The following is a description of a gene set: Mouse Gene Set: chr8D3 studied in species Mus musculus, and this is the list of marker genes: Gm45710, Mir140, Tmem208, Chst4, Psmd7 (NCBI Gene Id 17463), 5033426E14Rik, Vac14, Hp, Matr3-ps2, Gm3830, D030068K23Rik, Ddx28, Pla2g15, Ap1g1, Cmtm4, Thap11, Gm11020, B3gnt9, Hydin, Mir1966, Fbxl9, Esrp2, Enkd1, Gm16209, Hsd11b2, 4930578M07Rik, Gm5159, Ces4a, Mir7075, Matcap1, 4933405L10Rik, Zfp612, Gm16208, Nqo1, Fbxl8, Gm33023, Cmtm2a, Atp6v0d1, Zdhhc1, Rrad, Rps18-ps3, C630050I24Rik, Hsf4, Wwp2, Gm8838, Ces2c, Bean1, Ces2d-ps, Gm10073, Cdh1, Ces2h, Ranbp10, Fhod1, Gm5743, Vps4a, Gm5915, Gm45795, Tsnaxip1, Gm20163, Ctcf, Ciao2b, Mir7074, 1810019D21Rik, Tppp3, Nol3, Slc12a4, Dpep2, Cog8, Cklf, Gm1943, Gm17344, Mir328, Gm39244, Pard6a, Tradd, Gfod2, Utp4, Cdh16, Cmtr2, Gm45752, Ces2a, Dus2, Gm10629, Phaf1, Gm6831, Gm8798, Gm8940, Txnl4b, Cdh5, Ripor1, Pkd1l3, Edc4, Gm10631, Zfhx3, Tmed6, Pdf, Mir3108, Pdp2, Gm8804, Elmo3, Slc7a6, Marveld3, Gm25321, Smpd3, Nob1, Tle7, Ces2f, Gm45855 (NCBI Gene Id 108167548), Cdh3, Sntb2, Dhodh, Prmt7, Gm22148, Dpep3, Chtf8, Plekhg4, Tango6, Ces3a, Cmtm2b, Nip7, Acd, Kctd19 (potassium channel tetramerisation domain containing 19), Slc7a6os, Agrp, Ist1, 6030452D12Rik, Tk2, Zfp821, Rps26-ps1, Cyb5b, Pskh1, Gm45750, Cmtm3, Lcat, Terb1, 8030455M16Rik, Gm38250, Psmb10, Snord71, Lrrc36, Cmtm1, Nfatc3, Nrn1l, Dync1li2, Cenpt, 1700082M22Rik, Rpl10-ps2, Calb2, Ces2b, Ces2g, Slc9a5, Nfat5, Terf2, Gm22085, Nae1 (NCBI Gene Id 260355), 9230110F11Rik, Atxn1l, 1110028F18Rik, Nutf2, Gm5914, Lncbate1, Pmfbp1, Car7, Derpc, Phlpp2, 4932416K20Rik, Ces2e, Exoc3l, Ces3b, Ctrl, E2f4, Gm29682, Carmil2, Zfp90, Cbfb, Has3, Dhx38, Gm26832, Gm7208, K230015D01Rik, Gm22972, Tat